Given this list of marker genes Hipk2, Hmbox1, Hipk1, Mir222, Cdkn1b, here is a description of the gene set: miR-222 in exercise-induced cardiac growth studied in species Mus musculus Mouse Gene Set: WP_MIR222_IN_EXERCISEINDUCED_CARDIAC_GROWTH